Given this list of marker genes VNN1, KRT83, NDEL1, LIMK2, ALOX5AP, EIPR1, NSUN3, WIPF2, TLR3, RPH3A, USP10, BTG2, SOHLH2, TPTE, ASH1L, MTOR, FZD7, ADO, CLTC, RHEB, TRIB1, CNGA1, RNF34, COCH (cochlin), GCNT1, CACNB2, PFKM, SCRN3, AHSP, ANKRD12, PSMA7, NOP10, CYP4F12, PEX3, MGAM, MTO1, CDH10, PLIN2, ST8SIA4, ATG10, RPS6KA5, RALGPS1 (Ral GEF with PH domain and SH3 binding motif 1), NAV2, CAMK2A, STRADA, SPOP, GPR45, MON2 (NCBI Gene Id 23041), GDAP2, POGLUT1, UTP25, RGL1, CRYBG1, COG2, ZSCAN32, SH2D3C, AGGF1, CPS1, SUOX, KLF7, PCNX1, SLC17A5, GYPA, TLR1, EDN1, RAD17, SERPINB2, DAZL, ACSL1, MCL1, WDFY3, ZNF586, ELF1, TLR2, ARPC2, MTHFS, PIK3R4, CDH17, EMSY (EMSY transcriptional repressor, BRCA2 interacting), PROX1, TUBBP5, RLF, GFOD2, XRCC4, MAGEA6, RBMS1 (NCBI Gene Id 5937), MAN2A1, PUM2, MKLN1, TNFSF14, KIAA0319, C3AR1, UVRAG, ZKSCAN4, POLR2B, CYP2C19, RBM47, LIG4, CSTF1, RGS2, SGK1, CDC123, CDKL3 (NCBI Gene Id 51265), ATP6V1E1, B4GALT5, TLR6, RAB11FIP2, FAS, DHX32, TREML2, CCL8, HINFP, ABHD5, RTCB, PTPN21 (protein tyrosine phosphatase non-receptor type 21), VPS13D, CFHR4, KLF6, EGR1, ADAMTS1, BBC3, USP9X, PDE8A, PKNOX2, PTGS2, MFAP3, BTN1A1, ZNF133, PRDM4, ZNF654, TAX1BP1, FAM114A1, LMBRD1, FBXO9, MACIR, RNFT1, PUS3, CCR1, CD53, SCYL3 (SCY1 like pseudokinase 3), F2RL1, COA3 (NCBI Gene Id 28958), PIK3CG, KCNJ1, RAE1, MTF1, IL1B, VPS35, AFTPH, GIGYF2, ANAPC13, MAFB, LPAR6, FOXC1, SON, CSTPP1, GPR182, EGR2, BTN2A1 (NCBI Gene Id 11120), AP3B1, DIS3, PAFAH1B1, BMX, ZFYVE26, SEC23B, PTRH2, RBPJ, STXBP5L (NCBI Gene Id 9515), FABP2, DNMBP, MYO16, TP73, ZNF234, MOSPD2, SRR, CCNJL, FABP7, TNFAIP1, HCAR3, LINC00652, PNP, SPARCL1, USPL1, TLR8, CYP7A1, CDC40, ZBTB24, EGR3, KCNJ15, CEMIP, RNF17, DHX15, CXCL1, ALX1, MRPS22, SHOX, CHTOP, H2BC13, here is a description of the gene set: Objective: We hypothesized that type 1 diabetes (T1D) is accompanied by changes in gene expression in peripheral blood mononuclear cells (PBMCs) due to dysregulation of adaptive and innate immunity, counterregulatory responses to immune dysregulation, insulin deficiency and hyperglycemia. Research Design and Methods: Microarray analysis was performed on PBMCs from 43 patients with newly diagnosed T1D, 12 patients with newly diagnosed type 2 diabetes (T2D) and 24 healthy controls. One and four month follow-up samples were obtained from 20 of the T1D patients. Results: Microarray analysis identified genes differing in expression between newlydiagnosed T1D patients and controls at a false discovery rate of 0.05. Changes in expression of interleukin-1β (IL1B), early growth response gene 3 (EGR3), and prostaglandin-endoperoxide synthase 2 (PTGS2) resolved within four months of insulin therapy and were also observed in T2D suggesting that they resulted from hyperglycemia. With use of a knowledge base, 81/genes could be placed within a network of interrelated genes with predicted functions including apoptosis and cell proliferation. IL1B and the MYC oncogene were the most highly-connected genes in the network. IL1B was highly overexpressed in both T1D and T2D, whereas MYC was dysregulated only in T1D. Conclusion: T1D and T2D likely share a final common pathway for beta cell dysfunction that includes secretion of interleukin-1β and prostaglandins by immune effector cells, exacerbating existing beta cell dysfunction, and causing further hyperglycemia. The results identify several targets for disease-modifying therapy of diabetes and potential biomarkers for monitoring treatment efficacy. Human Gene Set: GSE9006_HEALTHY_VS_TYPE_2_DIABETES_PBMC_AT_DX_DN Genes down-regulated in comparison of peripheral blood mononuclear cells (PBMC) from healthy donors versus PBMCs from patients with type 2 diabetes at the time of diagnosis. studied in species Homo sapiens from publication Kaizer EC, Glaser CL, Chaussabel D, Banchereau J, Pascual V, White PC (PMID 17595242)